The following is a description of a gene set: from publication Cui A, Huang T, Li S, Ma A, Pérez JL, Sander C, Keskin DB, Wu CJ, Fraenkel E, Hacohen N (PMID 38057668) Mouse Gene Set: CUI_NK_CELL_IL1B_RESPONSE_UP studied in species Mus musculus Genes positively differentially expressed in cell type: NK cell upon treatment with cytokine: IL-1β in mouse lymph nodes in vivo. Cytokines mediate cell-cell communication in the immune system and represent important therapeutic targets. A myriad of studies have highlighted their central role in immune function, yet we lack a global view of the cellular responses of each immune cell type to each cytokine. To address this gap, the authors created the Immune Dictionary, a compendium of single-cell transcriptomic profiles of more than 17 immune cell types in response to each of 86 cytokines (>1,400 cytokine-cell type combinations) in mouse lymph nodes in vivo. A cytokine-centric view of the dictionary revealed that most cytokines induce highly cell-type-specific responses. For example, the inflammatory cytokine interleukin-1β induces distinct gene programmes in almost every cell type. A cell-type-centric view of the dictionary identified more than 66 cytokine-driven cellular polarization states across immune cell types, including previously uncharacterized states such as an interleukin-18-induced polyfunctional natural killer cell state., and this is the list of marker genes: Il2rb, Epb41, Pik3r1 (NCBI Gene Id 328326), Ets1 (E26 avian leukemia oncogene 1, 5' domain), Gimap5, Sipa1l1, Pabpc1, Irf8, Fryl, Paip2, Hmgb2, Tecpr1, Sh2d2a, P2ry10, Ptpn22, Metrnl, Emb, Sidt2, Fyb1, Cyld, Ifngr1, Crem, Abl1, Dgat1, Gpr171, Bcl2a1b, Ssh2, Eef2, Tsc22d3, Sft2d2 (NCBI Gene Id 98387), Irak2, Ctla2a, Bnip3l, Rab27a (RAB27A, member RAS oncogene family), Stat3, Pbxip1, Txnip, Hvcn1, H2-Aa (NCBI Gene Id 406213), Litaf, Serpinb6b, Itgb3, Bcl2l11, Bcl2, Fam107b, Srgn, Vps37b, Gimap3, Apobec3, Celf2, Serinc3, Klrb1b, Serpina3g, Jak1, Nsd3, Laptm5, Serpinb9, Cables1